The following is a description of a gene set: The localization process by which an autophagic substrate is delivered to a forming autophagosome. Human Gene Set: GOBP_SUBSTRATE_LOCALIZATION_TO_AUTOPHAGOSOME species: Homo sapiens, and this is the list of marker genes: BNIP3, RETREG2, TOM1, STBD1, RETREG3, SMURF1, IRGQ, RETREG1